Given this list of marker genes MIR103B1, MIR214, MIRLET7B, MIR544A, MIR98, AGO4, MIR663A, MIR24-1, MIR149, AGO1, MIR190B, MIR708, MIR200C, MIR34B, MIRLET7E, MIR96 (NCBI Gene Id 407053), MIR27A, MIR106A, MIR199B, MIR181A2, MIR26B, MIR501, MIR655, MIR519D, MIR608, MIR100, MIR340, MIR373, MIR93, MIR302C, MIR485, CNOT8, AGO3, MIR9-1, MIR145, MIR486-1, MIR625, MIRLET7A1, MIR495, MIR192, MIR23A, MIR4286, MIR135B (NCBI Gene Id 442891), MIR424, MIR146A, MIR137, MIR520C, MIR665, MIR203A, MIR20A, MIR128-1 (microRNA 128-1), MIR320A, MIR211, MIR181D, MIR483, MIR564, MIR130A, MIR326, MIR185, MIR223, MIR142, MIR133A1, MIR365A, MIR151A, MIR212, MIR517C, MIR517A, MIR30B, MOV10, MIRLET7C, MIR181B1, MIR302A, CNOT6, MIR125B1, MIR337, MIR181C, MIR491, MIR204, MIR1-1, MIR18A, MIR106B, MIR519A1, MIR193A, MIR497, MIR206, MIR423, MIR562, MIR19A, MIR20B, MIR195, MIR329-1 (microRNA 329-1), MIR125A, CNOT7, MIR29B1, MIR210, MIR543, MIR885, AGO2, MIR191, MIR19B1, MIR200B, MIR342, MIR27B, MIR130B, MIR140, here is a description of the gene set: Human Gene Set: GOBP_MIRNA_MEDIATED_GENE_SILENCING_BY_MRNA_DESTABILIZATION studied in species Homo sapiens An RNA interference pathway in which microRNAs (miRNAs) direct the cleavage of target mRNAs. Once incorporated into a RNA-induced silencing complex (RISC), a miRNA base pairing with near-perfect complementarity to the target mRNA will typically direct targeted endonucleolytic cleavage of the mRNA. Many plant miRNAs downregulate gene expression through this mechanism.